The following is a description of a gene set: A G protein-coupled receptor signaling pathway initiated by an extracellular purine or purine derivative binding to its receptor, and ending with the regulation of a downstream cellular process. studied in species Homo sapiens Human Gene Set: GOBP_G_PROTEIN_COUPLED_PURINERGIC_RECEPTOR_SIGNALING_PATHWAY, and this is the list of marker genes: ADCY5, GNAI2, ADA, P2RY1, NECAB2, ADORA1, ADORA2A, ADORA3, ADORA2B, P2RY12, CNTN2, ACP3